Given this list of marker genes MUTYH, DDB2, ZNF432, SIRT6, TDG, WRN, APTX, BLM, RBBP8, RECQL4, DCLRE1C, PCNA, DCLRE1B, NEIL3, RAD1, POLQ, TP63, DDB1, HMGB1, ERCC3, RAD18, SMC6, KDM4D, PARP1, XRCC1, MSH6, REV1, ERCC5, EP300, XRCC5, ERCC1, XRCC6, ERCC4, H2AX, RPA1, XNDC1N, OGG1, HMGB2, NEIL2, SDE2, NEIL1, BRCA1, CUL4B, DCLRE1A, PNKP, CYREN, APEX1, NBN, FANCG, NTHL1, HMCES, FEN1, RPA2, MSH3, POLD1, CREBBP, UNG, POLK, RAD23A, PARP2, MPG, AUNIP, RAD23B, RPS3, XPA, ERCC2, MSH2, CRY2, XPC, POT1, POLB, POLH, POLI, RPA3, TP53BP1, here is a description of the gene set: studied in species Homo sapiens Human Gene Set: GOMF_DAMAGED_DNA_BINDING Binding to damaged DNA.